Given this list of marker genes BRAF, ALK, ZEB2, HRAS, NRAS, RAF1, SOX5, here is a description of the gene set: Congenital giant melanocytic nevus The giant congenital nevus is greater than 8 cm in size, pigmented and often hairy. A giant congenital nevus is smaller in infants and children, but it usually continues to grow with the child. Human Gene Set: HP_CONGENITAL_GIANT_MELANOCYTIC_NEVUS studied in species Homo sapiens